The following is a description of a gene set: A motor activity that generates movement along a microtubule toward the plus end, driven by ATP hydrolysis. studied in species Homo sapiens Human Gene Set: GOMF_PLUS_END_DIRECTED_MICROTUBULE_MOTOR_ACTIVITY, and this is the list of marker genes: KIF3A, KIF3B, KIF5A, KIF19, KIF1A, KIF1C, KIF21A, KIFC2, KIF18A, KIF20B, KIF5B, KIF14, KIF5C, KIF1B, KIF16B, KIF18B, KIF17, KIF11, KIF15